Given this list of marker genes CHST14, B4GALT7, KNSTRN, TWIST1, CAMK2G, PLAAT3, LRP5, ITPR1, COG7, IL11RA, FGFR2, EXT2, ERI1, KCNH1, PIK3CD, RECQL4, IARS2 (isoleucyl-tRNA synthetase 2, mitochondrial), here is a description of the gene set: species: Homo sapiens Human Gene Set: HP_FLAT_FOREHEAD Flat forehead A forehead with abnormal flatness.